The following is a description of a gene set: Human Gene Set: HP_DELAYED_CRANIAL_SUTURE_CLOSURE Infants normally have two fontanels at birth, the diamond-shaped anterior fontanelle at the junction of the coronal and sagittal sutures, and the posterior fontanelle at the intersection of the occipital and parietal bones. The posterior fontanelle usually closes by the 8th week of life, and the anterior fontanel closes by the 18th month of life on average. This term applies if there is delay of closure of the fontanelles beyond the normal age. Delayed cranial suture closure studied in species Homo sapiens, and this is the list of marker genes: RNF125, BICRA (NCBI Gene Id 29998), HDAC4, FGFR2, IGF2, USP7 (ubiquitin specific peptidase 7), FAM20C, NCAPG2, PEX2, AMER1, GLI3, ZFX, H19, ATP7A, FLNA, ACTG1, GH1, PPP1R21, PTDSS1, ANTXR1, PEX19, SPEN, MTX2, MAF, CHST14, RNU12, ZIC1, TSHB, POLR3A, ALG9, PDGFRB, PEX14, GABRD, PROP1, BANF1, ASPA, PDPN, MED12, CASZ1, PRIM1, FBLN5, KCNAB2, SKI, CTSK, PRKCZ, ELN, HSD17B4, DSE, NSUN2, DUOX2, POU1F1, DDX6, FGFR3, ROR2, SH3PXD2B, PRDM16, LHX3, FAM111A, TG, TBCE, ANKRD11, LHX4, LMNA, TOMM7, ATP6V1A, SEC23A, TPO, CRTAP, SMC3, COL1A1, NLRP3, ALDH18A1, RPS6KA3, CREBBP, GRB10, ADAMTS2, ATP6V1E1, NAA10, IYD, EP300, LIG4, SLC5A5, UBE4B, MMP2, TWIST1, LUZP1 (leucine zipper protein 1), ZMPSTE24, ACTB, RERE (arginine-glutamic acid dipeptide repeats), HSPG2, MMP23B, RPS19, ATP6V0A2, DUOXA2, HESX1, RUNX2